The following is a description of a gene set: studied in species Mus musculus Mouse Gene Set: chr7F3, and this is the list of marker genes: Kdm8, 4930483O08Rik, Gm33248, 4933440M02Rik, Gm9333, Lcmt1, Zfp764l1, 1700120K04Rik, Sult1a1, 9430064I24Rik, Eef1akmt2, 2310057M21Rik, Zfp646 (NCBI Gene Id 233905), Dhx32, Zfp764, Gm24596, Foxi2, 4930451I11Rik (NCBI Gene Id 78118), Hmx3, 3100003L05Rik, Zfp553, Gm35147, Septin1, 4930513N20Rik, Aldoa, Uros, Cfap119, Tbc1d10b, Ppp4c, Gm9347, Gm6249, Armc5, Cln3, Sgf29, Snrp1c-ps1, Gm15483, Mir1962, Gm33146, Bcl7c, Bola2, Nupr1, Qprt, Gm9967, Gm4587, Dmbt1, Sephs2, Gm30928, Pycard, Ptpre, Gm9341, Gm5738, Hsd3b7, Gm32816, Zfp696, Phkg2, Mir3103, Cpxm2, Fbxl19, 1700008J07Rik, Itgax, Htra1, Gm7258, Gm36356, Katnip, Gm18600, Tlcd3b, Atp2a1, Gm24581, Gm4259, Smt3h2-ps2, Gm39091, Fus, AI467606, 1500002F19Rik, Hirip3, Eif3c, Cdipt, Gm25759 (predicted gene, 25759), Cd2bp2, Gdpd3, Gm15503, 1700123J17Rik, Spn, Zranb1 (zinc finger, RAN-binding domain containing 1), Gm10584, Gm19514 (NCBI Gene Id 100503026), Gm32884, Gm17831, Gm18561, Gm4265, Apobr, Slc5a2, Rgs10, Abraxas2, Inpp5f, Prss36, Gm40457, Glud-ps, Prss8, Etos1, Gm25579, Rusf1, Gm5903, Gm6939, Mir7061, Gm39090, Mapk3, Zfp668, Vkorc1, Kat8, Gm10578, Gm6916, Setd1a, 4930551E15Rik, Insyn2a, Gm17137, Gm33027, Mmp21, Gm31749, Ypel3, Gm36849, Nkx1-2, Gm45700, Zkscan2, 4931431B13Rik, Hs3st4, Gm4973, Fam53b, Prr14, Zfp689, Lhpp, Cdcp3, Tacc2, Gm35625, Bag3, Gm23445, Mylpf, Dock1, Mcmbp, Ino80e, C030029H02Rik, Fam24a, Coro1a, Fgfr2, Fam24b, 2200002A13Rik, Gm36737, Mir762, Btbd16, Kctd13, Acadsb, 5830432E09Rik, Stx1b (NCBI Gene Id 79361), Ctbp2, Wdr11, Sh2b1, Sez6l2, Ikzf5, Zfp768 (NCBI Gene Id 260390), Sbk1, Aqp8, 1700029B22Rik, Tgfb1i1, Mir7059, Stx4a, Bccip, Ctf1, Gm36431, Zfp688, A130023I24Rik (RIKEN cDNA A130023I24 gene), Lat, Gm34908, B130055M24Rik, Mgmt, Pagr1a, 1700120G07Rik, 4930533L02Rik, Cox6a2, Oat, Il21r, Gm4768, Gm23788, 2610306O10Rik, Doc2a, Chst15, 4930571K23Rik, Maz, Gm15533, Gm45241, 4933402N03Rik, Slc5a11, Dctpp1, Gm39094, Hmx2, Bub3, Orai3, C230079O03Rik, Plpp4, Nfatc2ip, Asphd1, Gpr26, Ctf2, 4930544L04Rik, Tmem265, Tial1, Prss53, Rnf40, Arhgap17, Gm57854 (NCBI Gene Id 129135233), Nsmce1, Zfp747, Zfp771, Zfp629, Gm5904 (NCBI Gene Id 546009), Xpo6, Nsmce4a, Cd19, Tex36, Trim72, Gm45502, Fank1, Gtf3c1, Spns1, Gm9299, Rabep2, Kif22, Mvp, 6330420H09Rik, Taok2, Srcap, Mki67, Mir7060, Clrn3, Tbx6, Gsg1l, Gm23168, Tufm, Gm16477, Pstk, Gm33080, Itgam, Adam12, Cdiptos, Itgal, Gm4585, Nps, Zg16, Fbrs, Gm6108, Snora30, Sec23ip, Slx1b, Atxn2l, Gm22809, Gm10155, Cuzd1, B930086L07Rik, Prrt2, Mir7058, Ate1, 4930448A20Rik, Tmem219, Gm19366, Gm5602, Plekha1, Zfp747l1, D7Ertd443e, Bckdk, Il27, Ebf3, Edrf1, Il4ra, Gm23847, Gm31897, Gm16044, Itgad (integrin, alpha D), Gm17511, Gm49368, Gm4275